The following is a description of a gene set: Human Gene Set: GOBP_POSITIVE_REGULATION_OF_PHOSPHOLIPID_TRANSPORT Any process that activates or increases the frequency, rate or extent of phospholipid transport. studied in species Homo sapiens, and this is the list of marker genes: APOE, FASLG, APOA1, DBI, ATP8A2, PRELID1, XRCC4, PRAP1, TMEM30A, CETP, ATP8A1, ABCA3, ABCB4, TRIAP1, ABCA7